Given this list of marker genes SIAH2, H2AC7, APOA4 (apolipoprotein A4), H2AC20, H4C1, CALB1, B2M, SNCA (NCBI Gene Id 6622), H2BC12L, APOE, NAT8, GGA2, H2AB1, CALCA, H3-3A, H3C1, APP, H2BC3, APOA1, H2BC4, UBE2L6, H2AZ1, HSPG2, SNCAIP, ODAM, SORL1, GGA3, H2BC1, NAT8B, TSPAN5, H2AC4, H2AC18, UBB, H2BC13 (H2B clustered histone 13), TSPAN33, IAPP, SIAH1, LTF, PSENEN, BACE1 (NCBI Gene Id 23621), FGA, FURIN, APCS, PRKN, H2BC17, APH1A (aph-1 homolog A, gamma-secretase subunit), TSPAN14, GGA1, TTR, MFGE8, H2AC14, PRL, H3C15, NPPA, H2AX, ITM2B (integral membrane protein 2B), ADAM10, USP9X, NCSTN, GSN, TSPAN15, CST3, H2BC12, SAA1, H2BC11, H2BC14, H2BC5, H2BC9, LYZ (lysozyme), TGFBI, H2BC15, UBA52 (ubiquitin A-52 residue ribosomal protein fusion product 1), H2AC6, INS, H2BC21, SEMG1, RPS27A, APH1B, H2BC26, UBC, here is a description of the gene set: part of: Metabolism of proteins Reactome Pathway: Amyloid fiber formation Amyloid is a term used to describe deposits of fibrillar proteins, typically extracellular. The abnormal accumulation of amyloid, amyloidosis, is a term associated with tissue damage caused by amyloid deposition, seen in numerous diseases including neurodegenerative diseases such as Alzheimer's, Parkinson's and Huntington's. Amyloid deposits consist predominantly of amyloid fibrils, rigid, non-branching structures that form ordered assemblies, characteristically with a cross beta-sheet structure where the sheets run parallel to the direction of the fibril. Often the fibril has a left-handed twist (Nelson & Eisenberg 2006). At least 27 human proteins form amyloid fibrils. Many of these proteins have non-pathological functions; the trigger that leads to abnormal aggregations differs between proteins and is not well understood but in many cases the peptides are abnormal fragments or mutant forms arising from polymorphisms, suggesting that the initial event may be aggregation of misfolded or unfolded peptides. Early studies of Amyloid-beta assembly led to a widely accepted model that assembly was a nucleation-dependent polymerization reaction but it is now understood to be more complex, with multiple 'off-pathway' events leading to a variety of oligomeric structures in addition to fibrils, though it is unclear whether these intermediate steps are required in vivo. An increasing body of evidence suggests that these oligomeric forms are primarily responsible for the neurotoxic effects of Amyloid-beta, alpha-synuclein and tau (Dance & Strobel 2009, Meraz-Rios et al. 2010). Amyloid oligomers are believed to have a common structural motif that is independent of the protein involved and not present in fibrils. Conformation dependent, aggregation specific antibodies suggest that there are 3 general classes of amyloid oligomer structures including annular structures which may be responsible for the widely reported membrane permeabilization effect of amyloid oligomers. Toxicity of amyloid oligomers preceeds the appearance of plaques in mouse models. <br>Fibrils are often associated with other molecules, notably heparan sulfate proteoglycans and Serum Amyloid P-component, which are universally associated and seem to stabilize fibrils, possibly by protecting them from degradation. studied in species Homo sapiens